Given this list of marker genes PRR13, SLC30A7 (NCBI Gene Id 148867), CD300LB, WDR45, ACOX1, TAX1BP1, GLIPR2, CD180, CARD19, SLC49A4, NOTCH1, TNFSF8, MAP2K1, CALHM2, PRTN3, ATP8A2, SH2D1B, STAU1, MEF2A, EMP3, WDR26, GOLM1, ATP8B4, FADS6, CLNK, CBFA2T3, SYNRG, GPM6B, CD5, CD244 (CD244 molecule), DNTT, LPCAT3, WDR7, ITGB7, TMEM176A, PIP4K2C, NAPSA, PTPRE, LASP1, UROS, CST7 (cystatin F), VGLL4, ATP6V0C, TYROBP, WDFY2, PRSS16, KIT, HGFAC, UVRAG (NCBI Gene Id 7405), RIT1, PTPN3, SNX3, TAX1BP3, ABHD12, PPP1R18, XRCC6, TAPT1, PCYT1A, HNRNPC, GPR174, PGLYRP2 (peptidoglycan recognition protein 2), PYGM, SLC36A1 (solute carrier family 36 member 1), TMEM167B, ANXA1, LGALS9B, NAB1, SERINC1, MOB3A, ATP6V0E1 (ATPase H+ transporting V0 subunit e1), SNN, NUDT18, SYNJ2, MYO1F, MIDN, FAM177A1 (family with sequence similarity 177 member A1), DYNLT2B, PHF21A, PTEN, IL18R1, GPRIN3, ABCB10, TOLLIP, HPGDS, GNG2, HAAO, CRYZL1, KLRD1, CYBA, LIMS4, NPY2R, RGS14, CCR2, PIGX, CEACAM21, IFNAR2, HORMAD1, SPECC1, ECI2, SLC43A2, IGFBP4, NCF1, ITGAL, HLA-DMA, SLC29A3, ATP6V0B, P4HB, TUBGCP5, GOLGA2, FBXW4, KHK, DECR1, RPS6KA1, C6orf62, ITSN1, NKG7, TXNIP (NCBI Gene Id 10628), GPX1, LDLRAD4, RRAD, LAT2, DLG4 (discs large MAGUK scaffold protein 4), TBC1D23, SLC35D3, PCDH11X, BLOC1S3, ISG20, PSTPIP1, DOCK8, CAMK2G, MAP7D2, BMP2K, ALOX5AP, ZMYND8, NRROS, IFNGR1, SRP72, NAP1L2, ITM2B, SLC35A1 (NCBI Gene Id 10559), ACOT7, MOCOS, RAI14, NBDY, PLEKHB2, YPEL3 (NCBI Gene Id 83719), ARFGAP3, CTSO, SYAP1, ARHGAP6, RAB11FIP5, AFF3, HLA-DOA, TRIOBP, GABARAPL1, MCFD2, CRLF2, LCK, TLR2, SRPK3, FCER1G, NQO2, CD2BP2 (NCBI Gene Id 10421), LINC00301, GOSR2, CACNB2, VEGFC, DERA, KLHL30, OAS2, SLC25A11, MRC1, EVI5, CHID1, PECAM1, NFE2, UNKL, UNC93B1, CLBA1, MAMDC2, SPTA1, DOCK10, PREX1, RNASEL, FXYD5, BCR, TLE6, LTB4R, ITM2C, MN1, LPGAT1, GPR146, TNS1, FYCO1, ABI3, LMO2, AKT2, ARHGEF4, ANKRD28, RAB27A, here is a description of the gene set: species: Homo sapiens Murine Cytomegalovirus (MCMV) infection leads to early activation of various immune cells, including B and T lymphocytes, before the actual initiation of antigen-specific adaptive immunity. This activation is partly driven by innate cytokines, including type I interferon (IFN), which are induced early after infection. The objective of this study was to address the role of type I IFN in shaping early/innate B and T cell responses to a primary acute viral infection. In order to decipher the specific impact of IFN-I on cell subsets, we performed a genome-wide expression analysis on WT splenic B and CD8 T lymphocytes isolated from C57BL/6 mixed bone marrow chimera mice. This study complements series GSE39555, which focused on early responses of NK cells and of the two subsets of conventional dendritic cells. Human Gene Set: GSE45365_NK_CELL_VS_CD11B_DC_MCMV_INFECTION_DN Genes down-regulated during primary acute viral infection: NK cells versus ITGAM+ dendritic cells.